The following is a description of a gene set: Human Gene Set: ZNF419_TARGET_GENES species: Homo sapiens from publication Yevshin I, Sharipov R, Kolmykov S, Kondrakhin Y, Kolpakov F (PMID 30445619) Genes containing one or more binding sites for (ZNF419) in their promoter regions (TSS -1000,+100 bp) as identified by GTRD version 20.06 ChIP-seq harmonization., and this is the list of marker genes: MTCO3P12, ANO8, GTPBP3, EXOSC5, GLYATL1, MTND5P11, BCKDHA (NCBI Gene Id 593)